Given this list of marker genes Xrcc5, Polq, Poll, Xrcc6, Hmga1, Polb, Polg, Hmga1b, Hmga2, here is a description of the gene set: Mouse Gene Set: GOMF_5_DEOXYRIBOSE_5_PHOSPHATE_LYASE_ACTIVITY Catalysis of the reaction: a 5'-end 2'-deoxyribose-2'-deoxyribonucleotide-DNA = (2E,4S)-4-hydroxypenten-2-al-5-phosphate + a 5'-end 5'-phospho-2'-deoxyribonucleoside-DNA + H+. species: Mus musculus